Given this list of marker genes Alox15, Gpx4, Lta4h, here is a description of the gene set: species: Mus musculus part of: Biosynthesis of EPA-derived SPMs Reactome Pathway: Biosynthesis of E-series 18(S)-resolvins electronically inferred by orthology from the curated human pathway This event has been computationally inferred from an event that has been demonstrated in another species.<p>The inference is based on the homology mapping from PANTHER. Briefly, reactions for which all involved PhysicalEntities (in input, output and catalyst) have a mapped orthologue/paralogue (for complexes at least 75% of components must have a mapping) are inferred to the other species.